Given this list of marker genes RASL10A, LRRC77P, ZBED3 (NCBI Gene Id 84327), PIGR, NLRP9, CORO6, CTNNBIP1, MTA3, PCDHGA10, LINC00315, MAGEF1 (MAGE family member F1), RBM3, ANKRD12 (NCBI Gene Id 55606), LINC01547 (NCBI Gene Id 84537), LINC01566, CLN3, CYLC1, ATP6AP2, ITFG1, NTRK2, CFAP46, KAT8, DYNLT3, ARL6IP5, CD48, MUCL1, PMS1, GNS, SNHG7, ACTL6A, ANP32A, MGAT4B (NCBI Gene Id 11282), PIGK, LLGL2, DNASE2, PCDHGB7, KCNK15-AS1, SLC22A17, LINC00612 (NCBI Gene Id 442755), KRTAP10-11, TREML3P, CPSF2, GLIS2, BEX5, LINC00309, XPC, PRTG, MAGEB2, ABHD4, SPARC (secreted protein acidic and cysteine rich), TMEM106B, ZNF135, CKMT2-AS1, LINC02092, GREB1L, GIMAP8, GABRA6, SSBP2, CLNK, MATN1-AS1, ZDHHC7, ADCY5, OXCT1, FCHSD2, SUGT1P3, GOLM2, RAP2B (RAP2B, member of RAS oncogene family), FYB2, CTNS (NCBI Gene Id 1497), PHF3, SNAPIN, SPATA31F1, PRDX4, ADD2 (NCBI Gene Id 130935), SLC25A29, DECR2, PSD2, CRADD (CASP2 and RIPK1 domain containing adaptor with death domain), TNFSF15, SRGAP2C, CBX5, TRAIP, PRKCSH, CCL28, RAX, CCDC28B, C5AR2, ZDHHC19, KANK2, ALOX12, LNPEP, TM2D3, PPT1, LDAF1 (lipid droplet assembly factor 1), PLS3, GABRG1, HMGCL, MAN1B1, NAALAD2, FAM229A, ZFP90, DNAJB14, NUDT16L2P, HYDIN2, PUM1, DDOST, DNAL4, TCAF2, THAP11, LINC02825, GSX1, MRFAP1L2, PSG4, PRKAB2, GGTLC1, ATRN, SMLR1, FAM78B, MPDZ, CYBB, SPATA31F3 (NCBI Gene Id 100129969), LINC01252, ENTPD5, ZC3H10, MROH8, KRTDAP, KRT222, AGBL1, SGK2, FOXN3, ZNF19, REXO6P, HADHB, ZFPM1, MED13L, EGLN3, PKD2L1, SRR (serine racemase), NACA4P, FGF11, ECH1, RERG, LIX1L, TWSG1, TMEM59, NEURL2, ASB16-AS1, CASQ1, ZFAND5, TM9SF2, ASH1L-AS1, SOCS2-AS1, TCEAL4, DVL2, CAVIN2, ADAM33, OLMALINC, CCDC17, TMEM143, CEP162, ZNF346, VMP1, RBL1, CLASP2, KHDC1, ALLC, VGLL2, SIAH1, PCNX4, C22orf23, SSR4, SH3BGRL, RPS13, ASAP3, SEPTIN8, DUSP19, EPB41, DCAF12L1, CLPS, ECM2, SLC4A10, SLC17A3, POLK, IFT122, FBXO10, OR2B2, FITM1, DTWD2, FBXO42, DNAH6, ZNF76, SLC16A6, CTDSPL2, LAPTM4A, here is a description of the gene set: Human Gene Set: GSE19772_CTRL_VS_HCMV_INF_MONOCYTES_DN Human cytomegalovirus (HCMV) induces pro-inflammatory monocytes following infection and we have evidence that phosphatidylinositol 3-kinase is a key mediator in this activation. To begin to address how this signalling pathway is responsible for the functional changes in infected monocytes, we examined the role this pathway played in the transcriptome of infected monocytes. Global transcriptional profiling using cDNA microarrays revealed a significant number of genes were regulated in a PI(3)K-dependent manner, identifying this pathway as a key cellular control point in the conversion of monocytes to an activated pro-inflammatory state following HCMV infection. from publication Chan G, Nogalski MT, Bentz GL, Smith MS, Parmater A, Yurochko AD (PMID 20173022) Genes down-regulated in monocytes: control versus HCMV infection. studied in species Homo sapiens